The following is a description of a gene set: The process in which the anatomical structures of a neuron projection are generated and organized into branches. A neuron projection is any process extending from a neural cell, such as axons or dendrites. species: Homo sapiens Human Gene Set: GOBP_NEURON_PROJECTION_ARBORIZATION, and this is the list of marker genes: GRIP1, SEMA3A, FZD4, ATG16L1, CC2D1A, NLGN1, MYO9A, WNT5A, NTNG2, MOV10, SPRY3, DVL3, LRP2, SSNA1, TPBG, LRRK2, MACF1, MFSD2A, BCL7A, ROCK1, MAP3K13, CHRNA7, PAK6, VPS13A, NTNG1, ZNF365, TAOK2, PTN, IGF2BP1 (NCBI Gene Id 201194), NRP1, TUBA1A, DVL1, DVL2, DLG4, SULT4A1, PHACTR1